The following is a description of a gene set: The infant leukemia-associated gene Ott1 (Rbm15) has broad regulatory effects within murine hematopoiesis. However, germ line Ott1 deletion results in fetal demise prior to embryonic day 10.5, indicating additional developmental requirements for Ott1. The spen gene family, to which Ott1 belongs, has a transcriptional activation/repression domain and RNA recognition motifs and has a significant role in the development of the head and thorax in Drosophila melanogaster. Early Ott1-deficient embryos show growth retardation and incomplete closure of the notochord. Further analysis demonstrated placental defects in the spongiotrophoblast and syncytiotrophoblast layers, resulting in an arrest of vascular branching morphogenesis. The rescue of the placental defect using a conditional allele with a trophoblast-sparing cre transgene allowed embryos to form a normal placenta and survive gestation. This outcome showed that the process of vascular branching morphogenesis in Ott1-deficient animals was regulated by the trophoblast compartment rather than the fetal vasculature. Mice surviving to term manifested hyposplenia and abnormal cardiac development. Analysis of global gene expression of Ott1-deficient embryonic hearts showed an enrichment of hypoxia-related genes and a significant alteration of several candidate genes critical for cardiac development. Thus, Ott1-dependent pathways, in addition to being implicated in leukemogenesis, may also be important for the pathogenesis of placental insufficiency and cardiac malformations. Genes down-regulated in hearts of E18.5 embryos upon knockout of VEGFA. from publication Raffel GD, Chu GC, Jesneck JL, Cullen DE, Bronson RT, Bernard OA, Gilliland DG (PMID 18981216) Mouse Gene Set: RAFFEL_VEGFA_TARGETS_DN studied in species Mus musculus, and this is the list of marker genes: Tlx1, Il18r1, Hey1, Hes1, Nkx2-5